The following is a description of a gene set: Glomerular deposits studied in species Homo sapiens An abnormal accumulation of protein in the glomerulus. Human Gene Set: HP_GLOMERULAR_DEPOSITS, and this is the list of marker genes: CFHR5, UMOD, SPRY2, MMP1, FN1, COL7A1, WDR19, NUP107, CFH, MME